Given this list of marker genes Dcp1b, Zfp36, Edc3, Edc4 (NCBI Gene Id 234699), Dcp1a, here is a description of the gene set: Cleavage of the 5'-cap of a nuclear-transcribed mRNA that is independent of poly(A) tail shortening. species: Mus musculus Mouse Gene Set: GOBP_DEADENYLATION_INDEPENDENT_DECAPPING_OF_NUCLEAR_TRANSCRIBED_MRNA